The following is a description of a gene set: Formation of apoptosome Mouse Gene Set: REACTOME_FORMATION_OF_APOPTOSOME studied in species Mus musculus, and this is the list of marker genes: Apip, Diablo, Mapk3, Aven, Gm10053, Apaf1, Mapk1, Cycs, Xiap, Casp9